The following is a description of a gene set: species: Homo sapiens Human Gene Set: GOBP_RESPONSE_TO_STEROL Any process that results in a change in state or activity of a cell or an organism (in terms of movement, secretion, enzyme production, gene expression, etc.) as a result of a sterol stimulus., and this is the list of marker genes: GRAMD1A, GRAMD1B, PMVK, INSIG2, DYNAP, RORA, INHBB, LRP6, NFE2L1, INSIG1, SMO (smoothened, frizzled class receptor), DAG1, F7, LRP8, TGFBR1, ABCA2, PTCH1, MIR96, RORC, SMAD2, MIR185, CYP7A1, MIR182, GRAMD1C, ABCA1, GPR155, TGFB1, CYP8B1, CCL3, CCR5, INHBA, MLC1, GPLD1, TGFBR2, CES1, OSBPL7